Given this list of marker genes XIAP, FASLG, CD247, IFNGR1, NFKBIA, NSMCE3, PTEN, FAS, SPIB, AICDA, IL12RB1, TNPO3, CD40LG, CASP10, DNMT3B, SEMA4D, POU2AF1, RASGRP1, IRF5, TNFSF15, OTULIN, MMEL1, GPR35, PIK3CD, VPS33A, MYD88, TPP2, IL12A, SPPL2A, SH2D1A, TCF4, MST1 (NCBI Gene Id 4485), PGM3, UNG, PIK3R1, CD40, KLHDC8B, IKBKG, here is a description of the gene set: An abnormally increased level of immunoglobulin M in blood. Increased circulating IgM level species: Homo sapiens Human Gene Set: HP_INCREASED_CIRCULATING_IGM_LEVEL